Given this list of marker genes Lif, Fgfr2 (fibroblast growth factor receptor 2), Col6a1, Sox2, Stk40, Gh, Mapk8ip3, Bloc1s6, Fgf10, Foxp2, Cldn18, Tmtc3, Abca12, Smpd3, Psen2, Man1a2, Flt4 (NCBI Gene Id 14257), Nkiras2, Sfta3-ps, Phf14, Scnn1b, Atxn1l, Igf1, Mmp12, Ptges3, Cic, Errfi1, Fbn1, Gata6, Hoxa5, Tcf21, Pdgfa, Ada, Tns3, Nkx2-1, Atxn1, Foxf1, Pgr, Sftpd, Hopx, Stra6, Tgfb3, Zfp157, Pthlh, Fgfr3, Selenon, Slc7a11, Bmpr2, Atp7a (ATPase, copper transporting, alpha polypeptide), Meg3, Tnrc6c, Itgb6, Creb1, Myocd, Foxa1, Pdpn, Asxl1, Tmem38b (transmembrane protein 38B), Pkdcc, Ace, Vegfa, Hs6st1, Tgfb1, Edn2, Fosl2, Igfbp5, Ltbp3, Nkiras1, Rc3h2 (NCBI Gene Id 77277), Bmp4, Man2a1, Kdr, Fgfr4, Mecp2, here is a description of the gene set: Mouse Gene Set: GOBP_LUNG_ALVEOLUS_DEVELOPMENT studied in species Mus musculus The process whose specific outcome is the progression of the alveolus over time, from its formation to the mature structure. The alveolus is a sac for holding air in the lungs; formed by the terminal dilation of air passageways.